Given this list of marker genes Tor1aip1, Usp18, Parp10, Laptm4a, Irf8, Sdc3 (NCBI Gene Id 20970), 9930111J21Rik2, Smchd1, Nt5c3, Gbp9, Ifit3, H2-K1, Epsti1, Asb13, Trim30d, Psme2, Art2b (ADP-ribosyltransferase 2b), Jaml, Ms4a6b, Gzma, Celf2, Ms4a6d, Morc3, Ubb, Pttg1, Smg7, Ly6e, H2-Q7, Psmb8, Cysltr2, Gng12, BC051226, Dhx58, Irf7, Aldoa, Cycs, Pgd, Slfn1, Ddx60, H2-T22, Pnpt1, Ddx24, Herc6 (hect domain and RLD 6), Nlrc5, Gbp6, Pdia3, Trafd1, Csrp1, Itm2b, Trim30a, Ifi35, Ccdc50, Treml2, Rigi, Ifit1, Slc25a22, Fnbp4, Oas3, Akr1b1, Ifi213, Anxa6, Rasa4, Trim14, Irgm1, Card11, Tasor2, Tent4a, Calr, Ttc39b, Usp25, Ifitm3, Oas1a, Samd9l, Parp12, Aftph, Icam1, Igtp, Mx1, Clic4, Mycbp2, Itm2c, Bst2, Tcstv4, Srsf3, Ywhaz, Cyth1, Tmbim6, Tmem140, Sp110, Parp11, Tap2, Hsh2d, Znfx1, Daxx, Gbp5, Naa20, Casp8, Tnfsf10, Acadl, Isg20, Ccnd2, H2-T23, Trim34a, Msn, Cd69, Dbnl, Ezr, Sp100, Gbp7, Cited4, Lgals3bp, Xaf1, Gbp4, Trim26, Ppp3ca, Psma2, Psme2b, Zc3hav1, Oasl1, Txn1, Ifit2, Zup1, Slfn5, Psmb10, Nampt, Hsp90ab1, Rtp4, Lamp2, Ifih1, Psmb9, Arl6ip1, Phf11c, Helz2, Trim56, Ppa1, Vps54, Stat2, Plac8, H2-Q4, Mndal, Tapbp, Chmp4b, Cd47, Tgtp2, Max (Max protein), Dtx1, Ncoa7, Phf11b, Ascc3, Rab5c, Tmem184b, Phyh, Ube2l6, Parp9, Fam111a, Smox, Lgals9, B2m, Bbx, Apobec3 (apolipoprotein B mRNA editing enzyme, catalytic polypeptide 3), Parp14, Ifi47, Tor3a (NCBI Gene Id 30935), Samhd1, Slco3a1, H2-D1, Cnp, Isg15, Keap1, Ifit1bl1, Stat1, Tbrg1, Ogfr, Itpr1, Fchsd2, Casp4 (NCBI Gene Id 12363, caspase 4, apoptosis-related cysteine peptidase), Mrpl30, Atp8a1, Nmi, Psma4, Clec2d, Ubald2, Aida, Prrc2c, Tmem106a, Cxcl10, Map2k1, Ccrl2, Ifi27l2a, Arhgap26, Gbp3 (NCBI Gene Id 99898), Rbm3, Psma5, Ifit3b, Slfn2, Dpp4, Camk2d, Oas2, Cd86, Tspo, Phf11a, Plscr3, Uba7, Atp10a, Cd274, Tfam, Hspa5, Ctss, Ndufaf8, Pcgf5, Iigp1, Pomp, Ifi44, Trim12c, Isoc1, Plaat3, Socs1, Trim30c, Adar, Selenow, Irgm2, Tor1aip2, Calhm6, Xdh (xanthine dehydrogenase), Hmgn3, Zcchc2, Phc2, Sp140, Ifi214, Hspa8, Ly6a, Idnk, Rsad2, Tmsb10, Rnf114, Ifi206, Psme1, Tut4, Tdrd7 (tudor domain containing 7), Clic1, Mitd1, Pml, B4galt5, Oasl2, Irf1, Capza2, Slamf7, Snx2, Dtx3l, Ifi209, Zbp1, Tcof1, Etnk1, Ms4a4c, Mov10, Gbp8, Il2rg, Myd88, Eif2ak2, Cmpk2, Rbl1, Ms4a4b, Hk1, Lgals8, Ifi203, Trim12a, Irf9, Rfc3, Tap1, Ogfrl1, Jak2, Gadd45g, St6galnac4, Shisa5 (NCBI Gene Id 67794), Gbp2, Trim25, Phip, Ifi208, Ilrun, Herc3, Slfn8, Grn, Tgtp1, Grina, Ifi204, Rnf213, H2-Q6, Arf4, here is a description of the gene set: Mouse Gene Set: CUI_T_CELL_GD_IFNA1_RESPONSE_UP Genes positively differentially expressed in cell type: γδ T cell upon treatment with cytokine: IFN-α1 in mouse lymph nodes in vivo. species: Mus musculus Cytokines mediate cell-cell communication in the immune system and represent important therapeutic targets. A myriad of studies have highlighted their central role in immune function, yet we lack a global view of the cellular responses of each immune cell type to each cytokine. To address this gap, the authors created the Immune Dictionary, a compendium of single-cell transcriptomic profiles of more than 17 immune cell types in response to each of 86 cytokines (>1,400 cytokine-cell type combinations) in mouse lymph nodes in vivo. A cytokine-centric view of the dictionary revealed that most cytokines induce highly cell-type-specific responses. For example, the inflammatory cytokine interleukin-1β induces distinct gene programmes in almost every cell type. A cell-type-centric view of the dictionary identified more than 66 cytokine-driven cellular polarization states across immune cell types, including previously uncharacterized states such as an interleukin-18-induced polyfunctional natural killer cell state. from publication Cui A, Huang T, Li S, Ma A, Pérez JL, Sander C, Keskin DB, Wu CJ, Fraenkel E, Hacohen N (PMID 38057668)